The following is a description of a gene set: studied in species Mus musculus The somatic process allowing for the production of immune receptors whose specificity is not encoded in the germline genomic sequences. Mouse Gene Set: GOBP_SOMATIC_DIVERSIFICATION_OF_IMMUNE_RECEPTORS, and this is the list of marker genes: Tcf7, Nuggc, Mlh1, Il4, Mad2l2, Clcf1, Polm, Xrcc6, Nbn, Ung, Rnf168, Exo1, Bcl11b, Tbx21, Shld3 (NCBI Gene Id 113002583), Ctnnbl1, Dclre1c, Nsd2, Aicda, Paxip1, Bcl6 (NCBI Gene Id 12053), Ifng, Hspd1, Nhej1, BC037156 (NCBI Gene Id 494497), Dcaf1, Shld2, Atm, Foxp1, Mcm3ap, Parp3, Pcyt1a, Rnf8, Pagr1a, Yy1, Msh3, Ptprc, Stat6, Rag1, Kmt5c, Cd40lg, Polq, Kmt5b, Lef1, Ccr6, Tfrc, Ezh2, Samhd1, Il2, Prkdc, Sanbr, Cyren, Shld1, Rif1, Ercc1, Msh2 (mutS homolog 2), Xrcc4, Polb, Ighd, Pms2, Il27ra, Mir181b-2, Cd40, Hmgb1, Hmces, Foxp3, Aplf, Icosl, Tcf3, Adar, Tgfb1, Tnfsf13, Batf, Nfkbiz, Lig4, Supt6, Cd28, Ndfip1 (Nedd4 family interacting protein 1), Msh6, Trp53bp1, Rag2, Slc15a4, Swap70, Mir181b-1, Atad5, Tnfsf4, Exosc6, Exosc3